The following is a description of a gene set: Any process that activates or increases the frequency, rate or extent of apoptotic signaling pathway. Mouse Gene Set: GOBP_POSITIVE_REGULATION_OF_APOPTOTIC_SIGNALING_PATHWAY studied in species Mus musculus, and this is the list of marker genes: Trp53, Il20ra, Pak2, Styxl1, Taf6, Myc, Trp73, Cyct, Casp2, Sod1, Traf2, Hyal2, Gper1, Fasl, Bid, Inhbb, Bclaf1, Agtr2, Cd40lg, Ubb, Thbs1, Prkcd, Ctsh, Osm, Cav1, S100a8, Becn1, Alox12, Camk2b, Unc5b, Rps7, Ei24, Traf7 (NCBI Gene Id 224619, TNF receptor-associated factor 7), Pten, Mtch2, G0s2, Ing5, Nfatc4, Fbh1, Stk3 (NCBI Gene Id 80435), Plagl2, Mal, Adora2a, Jak2, Cyld, App, Inca1, S100a9, Pdcd7 (NCBI Gene Id 97539), Bub1, Tgfbr1, Gsdma3, Sfrp1, Tnfsf15, Adcy10, Bok, Siglec1, Psen2, Tpd52l1, Fas, Bcl10, Nherf1, Bcl2l14, Ctsc, Srpx, Tnf, Spop, Clu, Ddit3, Atf3, Ppp2r1a (protein phosphatase 2, regulatory subunit A, alpha), Cradd, Rad9a, Tlr4, Daxx, Rps3, Gsdme, Jak3, Nck2, Eef1e1, Il19, Inhba (inhibin beta-A), Htra2, Bbc3, Apaf1, Ripk1, Rbck1, Mapk8, Dapk3, Tnfsf11, Skil, Pias4, Flcn, Ppp1ca, Nacc2, Tnfrsf12a, Stk4, Nkx3-1, Park7, Nf1, Pml, Plscr1, Septin4, Zswim2, Fbxw7, Mcl1, Tnfsf12, Maged1, Tnfsf10, Itm2c, Bax, Tgfb2, Mapk9, Wwox, Lck (lymphocyte protein tyrosine kinase), Siah1a, Serinc3, Knl1, Ltbr (NCBI Gene Id 21932), Fadd, Eif2ak3, Pmaip1, Msx1, Pea15a, Steap3, Tnfsf14, Sfpq, Trim39, Vnn1, Trp63, Lta, Agt, Prkra, Ptprc, Wnt5a, Ctnna1, Pycard, Runx3, Mmp2, Sirt1, Bcl2l11, Tlr6, Ptpn2 (protein tyrosine phosphatase, non-receptor type 2), Bmpr1b, Fis1, Faf1, Ret, Dedd2, Ripk3, Bcap31, Nox1, Trps1, Sh3glb1, Ppp2r1b, Nupr1, Dnm1l, Dab2ip, Bmf, Rpl26, Rack1, Siah1b, Casp8, Bad, Nck1, Pdia3, Ngfr, Rnf183, Bmyc, Ifnb1, Ltb